The following is a description of a gene set: The gene expression profile of peripheral Foxp3+ natural regulatory T cells isolated from Foxp3/EGFP bicistronic mice was compared to that of in vitro-induced regulatory T cells and to CD4+ conventional (Foxp3-) T cells. The role of the regulatory T cell transcription factor Foxp3 in shaping the transcriptosomes of natural and induced regulatory T cells was analyzed using mice expressing a mutant FOXP3-EGFP fusion protein (Foxp3deltaEGFP). We used gene expression microarrays to examine the transcriptional programs of natural and induced regulatory T cells and the function of Foxp3 in organizing the transcriptosomes of the respective cell type from publication Haribhai D, Lin W, Edwards B, Ziegelbauer J, Salzman NH, Carlson MR, Li SH, Simpson PM, Chatila TA, Williams CB (PMID 19265124) Genes down-regulated in T reg: induced versus failed induced. species: Homo sapiens Human Gene Set: GSE14415_INDUCED_TREG_VS_FAILED_INDUCED_TREG_DN, and this is the list of marker genes: S100A11, LMAN2, CASP3, CD48, ITGAM, MCM6, FKBP5, APOBEC2, CXCL10, RABGAP1L (NCBI Gene Id 9910), PREX1, REEP5, PFKP, MYO1F, GLCCI1, FAR1, CD38, SRGAP3, SH2D1A, XCL1, CHSY1, EOMES, SNX10, SLC25A24, TEC, TOX, RBBP8, DNAJB11, GADD45B, RSAD2 (radical S-adenosyl methionine domain containing 2), CDC14A, IFIH1, ARHGAP26, SUOX, EHD4, L1CAM, RUNX2, ERCC6L, PSMD14, SEPTIN4, SRGN, SH2D2A, DUSP5, FARP1, ACSL5, NSMAF, S100A13, EEA1 (NCBI Gene Id 8411), TSGA10, LAX1 (NCBI Gene Id 54900), PTGR1, ARHGAP19 (NCBI Gene Id 84986), XDH, RAD54B, PSMB8, COBLL1, LAG3, CD200R1L, PTGER4, ATP6V1F, CST7, ZBTB38, GSAP, AIF1, ELL2, LIME1, ARAP2, CD7, AHNAK (AHNAK nucleoprotein), ZEB2, CDCA5, ECH1, LY86, EHBP1L1, RGS2, ICOS, EZH2, HNRNPLL, NEK2, TBCB, SLA, BAG1, MICAL1, PSMA1 (NCBI Gene Id 5682), RANBP17, CRYBG1, USP18, MX1, PBX3, KIF14, LPIN2 (lipin 2), ALCAM, PRPF38A, INSL6, MYO5A, TRAFD1 (TRAF-type zinc finger domain containing 1), SWAP70, CRMP1, DDX28, CENPA, GBP3, CYSLTR2, CELA1, CARHSP1, RGS1, PRF1, CHAF1B, LRRFIP2, PTGER2, GIMAP4, ASRGL1, LAMC1, SMPDL3B, PMAIP1, INCENP, RBL2, JDP2, PTPRJ, BRCA1, VAMP8, MYADM, ARHGAP18, BRCA2, CLSPN, FCER1G, CXCR6 (NCBI Gene Id 10663), ETFB, MCM4, ING2, FRMD4B, PPM1J, NAB1, SH3GLB1, GALNT3, SDF2L1, DHX58, RAB1A, AP1S2, SYPL1, SEMA4D, TTK, ATF6, PRDM1, PERP (NCBI Gene Id 64065), CHIT1, NBEAL2, NR4A2, ABHD5, COX8A, STARD10, RORA, PLSCR1, KLRC2, TMEM163, PNP, IL15RA, ECT2, PHF11, SLAMF1, IL10RA, RRBP1, ITGA2, PTTG1, BEX3, CD44, GSR, CHST11, ITGAL, H2BC4, NCALD, ACADL, CETN2, SYT11, MTPN, F2R, AZIN1, NCAPD2, LRPAP1